Given this list of marker genes Trip11, Tmem190, Eqtn, Izumo3, Creb3l4, Cd46, Spaca4, Tmem225, Spaca1, here is a description of the gene set: species: Mus musculus The acrosomal membrane region that underlies the acrosomal vesicle and is located toward the sperm nucleus. This region is responsible for molecular interactions allowing the sperm to penetrate the zona pellucida and fuses with the egg plasma membrane. Mouse Gene Set: GOCC_INNER_ACROSOMAL_MEMBRANE